The following is a description of a gene set: studied in species Homo sapiens Genes encoding proteins involved in oxidative phosphorylation. Human Gene Set: HALLMARK_OXIDATIVE_PHOSPHORYLATION from publication Liberzon A, Birger C, Thorvaldsdóttir H, Ghandi M, Mesirov JP, Tamayo P (PMID 26771021), and this is the list of marker genes: ATP6V0C, MDH2, VDAC3, NDUFAB1, LDHB, GRPEL1, GPI, NDUFS4, NDUFC2, PHB2, NDUFS6, ATP5PB, HADHA, ATP5ME, SUCLG1, UQCR10, COX5A, UQCR11, SURF1, ATP6V1G1, ATP6V1D, BAX, IDH3G, GLUD1, ATP5F1E, ACADM, CYB5R3, UQCRFS1, IDH3A, UQCRB, COX17, SLC25A11, MRPL11 (mitochondrial ribosomal protein L11), NDUFA2, MPC1, NDUFS1, ISCA1, ATP6V1E1, ETFB, UQCRH, NDUFB1, ATP5MG, ATP5F1D, ATP5F1B, NDUFA9, GPX4, SDHD (succinate dehydrogenase complex subunit D), HCCS, SLC25A4, MRPS15, ALAS1, SUPV3L1, DECR1, NDUFB7, COX6C, TIMM17A, COX11, SLC25A6, ATP6V1C1, TIMM50, VDAC2, MTX2, NDUFS3, COX5B, ACAT1 (acetyl-CoA acetyltransferase 1), OAT, ATP5MC1, ATP5F1A, NDUFC1, TCIRG1, DLD, CYCS, AFG3L2, NDUFA1, MRPS12, ACAA1, NDUFB4, CYB5A, LRPPRC, ATP6V1F, ECHS1 (NCBI Gene Id 1892), BCKDHA, OPA1, NDUFB2, SLC25A5, NDUFA6, ALDH6A1, NDUFA5, GOT2, MRPS22, FDX1 (ferredoxin 1), CASP7, COX8A, ISCU, PMPCA, COX7C (cytochrome c oxidase subunit 7C), MAOB, UQCRQ, IMMT, COX15, ABCB7, ATP6V0B, MRPL35, FXN, SDHC, ATP6AP1, IDH2, FH, RHOT1, ATP1B1, UQCRC1, SUCLA2, COX10, SDHA, MRPL34, NDUFS8, ATP5MC3, MTRF1, NDUFV1, OGDH, UQCRC2, CYC1, ATP5F1C, TOMM22, NDUFA8, AIFM1, SDHB, PDK4, POLR2F, ACAA2, ATP5MF, SLC25A20, ECH1, HSPA9, COX6B1, COX7A2, NDUFB3, CS, POR (cytochrome p450 oxidoreductase), MRPS11, TOMM70, MTRR, NDUFB8, ETFA, ATP6V1H, NQO2, PRDX3, TIMM13, IDH1, DLAT, ATP5PO, TIMM8B, TIMM9, COX7B, NDUFB6, PDHB, MFN2, PDHA1, DLST, ACO2, ATP5PD, CPT1A, HSD17B10, MRPL15, NDUFS7, ATP5PF, NDUFV2, ATP5MC2, HADHB, ECI1, VDAC1, NDUFS2, SLC25A3, SLC25A12, NDUFA4, BDH2, MDH1, PHYH, RHOT2, NDUFB5, OXA1L, NNT, ACADSB, MGST3, COX4I1, COX6A1, PDHX, IDH3B, LDHA, TIMM10, HTRA2, ATP6V0E1, NDUFA3, RETSAT, ACADVL, COX7A2L, MRPS30, PDP1, NDUFA7, ETFDH